The following is a description of a gene set: electronically inferred by orthology from the curated human pathway part of: Transcriptional Regulation by MECP2 Reactome Pathway: Regulation of MECP2 expression and activity studied in species Mus musculus This event has been computationally inferred from an event that has been demonstrated in another species.<p>The inference is based on the homology mapping from PANTHER. Briefly, reactions for which all involved PhysicalEntities (in input, output and catalyst) have a mapped orthologue/paralogue (for complexes at least 75% of components must have a mapping) are inferred to the other species., and this is the list of marker genes: Sin3a, Lbr